The following is a description of a gene set: Genes down-regulated in comparison of NK cells versus monocyte macrophages. species: Homo sapiens Each fraction of mouse hematopoietic cells was purified by cell sorting from bone marrow of 8-week-old C57BL/6 mice, and its gene expression was analyzed. Human Gene Set: GSE27786_NKCELL_VS_MONO_MAC_DN from publication Konuma T, Nakamura S, Miyagi S, Negishi M, Chiba T, Oguro H, Yuan J, Mochizuki-Kashio M, Ichikawa H, Miyoshi H, Vidal M, Iwama A (PMID 21540074), and this is the list of marker genes: DEPDC1B (DEP domain containing 1B), ADA, GARIN1B, SH3YL1, MXI1, TIAM1, RFFL, BCL2L10, CCDC146, ACKR2, EMP3, FTMT (ferritin mitochondrial), RAB27A, TAL2 (NCBI Gene Id 6887), NHSL2, STRN, PIK3CG, CRIP3, DTX4, YAF2, ZNF469, PRPS1L1, MFSD6L, AMPD2 (adenosine monophosphate deaminase 2), PPM1L, RPIA, DYNLT2B, SLC6A12, CENPM, TMEM102, DSCAM, H2AX, SLC22A12, NDST1, GAREM1, LRR1, NUP43, COQ4, KLF17, CHIT1, SSX2IP, NDUFS4, LMAN2L, DENND11, MPP7, TCF15, NEU2, DTNBP1, ST8SIA5, DYNLT1, ARHGEF4, CHST12, RAC2, CFAP119, RNF14, SLC22A15, AUNIP, C3orf52, DHRS1, GRK4, HOMEZ, LPGAT1, GJA5, PHF10, CYP4F2, KBTBD7, STK31, MYL2, RABIF, MAB21L3, DHCR24, CNIH4, VAMP3, CFAP263, SLC22A17, POLR3K, UPP1, UROC1, SORT1, PROSER2, COTL1, SLC5A5, BCAR3, ISX, PLCB2 (NCBI Gene Id 5330), IL18BP, MORN3, GPSM3, CCDC34, MYOF, ID1, GLIPR2, CHRNA9, RGS19, EPN2, ALDOA, CHRNA5, GABPB1, RALGAPA1, NDC80, LECT2, TESC, F3, MCTP1, MYCL, HOXD9, PPP2CB, CCDC180, SEC22B (NCBI Gene Id 9554), IQGAP3, SEPTIN12, LPCAT4, GATAD1, TFF3, HLX, KNL1, EVI2B, KRT71 (keratin 71), NEK2, HIBCH, HJURP, PDE9A, FLNA, GPD1L, MAP3K10 (mitogen-activated protein kinase kinase kinase 10), TMEM104, ASPM, LMNTD2, PDE11A, UBXN11, OLIG3, KISS1R, CLEC6A, STRADB, ZFP30, PPP3CA, SMC4, PACRG, MYOZ1, CDC25C, USP13, KNTC1, SLC26A2, MVB12B, CWH43, ARHGAP10, BMPR1A, OOEP, GP1BA, ADARB2, CCNYL1, OVOL2, MYL1, MIR1915HG, PRKAR1B, ERCC6L, RIOK3 (NCBI Gene Id 8780), ABHD5, TSPOAP1, SRPX, CTDSP1, LAMP2, CITED2, PRNP, PAX7, RSPH6A, AFF2, SPMIP4, STAP2, HAND1, FOXB2, GFI1, HIC2, HNRNPLL, FHIP1A, SH2B1, TNFRSF17, TCAF1 (NCBI Gene Id 9747), COX19, GNA15, SCCPDH, SNED1, CACNG5, SLC51A, UCHL5, BAZ2B, G6PD, PALM, ADAMTSL3, PELI2, DKK3 (NCBI Gene Id 51583), ME3, E2F8, MZT2B, GYG1, PKM, FBXL19, CEP152, AFF1, OXT